Given this list of marker genes TBX4, RSPO2, CTSK, WNT3, TBCK, here is a description of the gene set: Acromelia species: Homo sapiens Shortening of the extremities affecting primarily the distal parts of the limbs (hands and feet) in relation to the other segments of the limbs. Human Gene Set: HP_ACROMELIA